The following is a description of a gene set: from publication Durante MA, Kurtenbach S, Sargi ZB, Harbour JW, Choi R, Kurtenbach S, Goss GM, Matsunami H, Goldstein BJ (PMID 32066986) Human Gene Set: DURANTE_ADULT_OLFACTORY_NEUROEPITHELIUM_RESPIRATORY_COLUMNAR_CELLS studied in species Homo sapiens, and this is the list of marker genes: PERP, AQP5, PRDX1, TACSTD2, KRT23, HSPB1, AQP3, FABP5, TXN, ANXA2, KRT19, NTS, SLC25A5, CD9, SERPINB3 (serpin family B member 3), SERPINB4, ALDH3A1, KRT6A, EPAS1, CLDN4, SFN, KRT8, CSTB, S100A16, MT1X, KRT18, ELF3, KLF5